Given this list of marker genes MS4A6A, TEX261, MGAT2, C19orf12, ACLY, PPM1G, C6orf58, ISCA2, ARF1, RNFT1, DACH1, ATP8B2, MSL1, BACH1, ST3GAL4, UQCC1, CCL13, MED23, CDK2, CYTH3, TOR3A, ANAPC1, NTHL1, KRTAP13-1, MAK, TMED7, TM9SF3, KMT5B, GALNT11, MRPL3, EFL1, SLC37A4, CAPZA2, HMGXB4, POLR1B, TAFAZZIN, ARHGAP21, SSBP3, HNRNPF, ANKRD28, EEF1G, FOXO3, LRP2, PDE6D, TM7SF3, UBA7, FIGNL1, NEK9, APP, CCND3, TNRC6B, TM6SF1, KCNK13, TMEM230, ATP6V0B, YWHAQ, VPS29, NDUFA9, ITSN1, IDH3A, CAPN3, TBCEL, IP6K1, RELA, HSD17B7, MIGA2, DOCK8, SLC9A1, NRDE2, ATPAF2, AKIRIN2, CDC25A, TTC7B, ADAM9, PIGH, WBP11, RXFP2, ZSCAN26, POLK, SURF1, MSH3, MFSD14A, RAD17, SLC66A2 (NCBI Gene Id 80148), MERTK, FAM3C (FAM3 metabolism regulating signaling molecule C), RSRP1, RAP2A, IGFBP4, MYH4, FNTA, DCTN5, LAMP2, ATG10, PLSCR3, ASPH, SIKE1, TAF9, SUGP2, FBXO25, LRRK1, LLGL1, TRIM7, MIS18BP1, RANBP10, RMND5A (required for meiotic nuclear division 5 homolog A), HLA-DRB1, SH2D1B, PCNX3, ORC5, MFN2, SERP1, DIPK2A, ABHD17A, TUBGCP3, BRCC3, CLDND1, USP38, ASB13, SOS1, RRP8, VPS33B, ZNF346, B4GALT6, AHRR, TXLNB, NFATC2IP, GATC, PHKA1, ZDHHC7, CHMP1A, RHBDD1, TRAPPC2B, ITM2A, PIBF1, CHTF8, ZNF426, MEF2D, TMEM51, POLR3A, CLINT1, AKTIP, GABRB2, CIPC, TBC1D14, KMT2E, MAPK1, DBF4, FBXO32, TMEM229B, RREB1, CEACAM21, MEF2C, NFIL3, MCAM, CCNE2, SLC44A2, PFN1, GMFB, FNTB, WSB1 (NCBI Gene Id 26118), SLC22A17, P2RY12, NCOA1, NT5C, SIRT7, KRTAP4-12, HNRNPD, CDKN2AIPNL, CCNT2, RAB43, CRCP, ZCCHC10, BMAL1, SYNGR1, CUL4A, TRIM25, ZKSCAN3 (NCBI Gene Id 95379), DNAJC21, ARPC4, RAB33B, RIPOR2, ELMO2, EPN1, IRF2, CNOT3, GPR65 (G protein-coupled receptor 65), RAB40C (NCBI Gene Id 64715), ANKMY2, JADE1, SRCAP, TMEM41B, SELENOP, CAMKV, LGALS9B, DHRS7B, DCAF15, SIGIRR, CEP350 (NCBI Gene Id 9857), VPS39, here is a description of the gene set: species: Homo sapiens from publication Amit I, Garber M, Chevrier N, Leite AP, Donner Y, Eisenhaure T, Guttman M, Grenier JK, Li W, Zuk O, Schubert LA, Birditt B, Shay T, Goren A, Zhang X, Smith Z, Deering R, McDonald RC, Cabili M, Bernstein BE, Rinn JL, Meissner A, Root DE, Hacohen N, Regev A (PMID 19729616) Genes down-regulated in comparison of dendritic cells (DC) stimulated with Pam3Csk4 (TLR1/2 agonist) at 2 h versus DC cells stimulated with Gardiquimod (TLR7 agonist) at 2 h. Human Gene Set: GSE17721_PAM3CSK4_VS_GADIQUIMOD_2H_BMDC_DN mouse primary BMDCs were stimulated with tlr ligands and gene expression changes were profiled on Affymetrix arrays